Given this list of marker genes LAT, GP1BB, FAM3C, FDPS, TFRC, NUP107, ETF1, RRP1B, HK2, ACKR1, CLU, CHAC1, PBX1, KLF1, ST3GAL6, PLAGL2, TMEM132A, JMJD6, DIAPH3, ASNS, PFAS, ARHGAP29, TXNDC5, CTPS1, SLC2A1, NT5C3A, RABGEF1, RCOR1 (NCBI Gene Id 23186), IRAG1, GBX2, ZNRD2, TRMT61A, ZFPM1, GPAT4, PIGT, PDCD4, EGR1, NOMO1, TACC1, GUCY1A1, DCTD, FHL1, PARM1, MTHFD2, SCD, SHMT2, SEMA4B (NCBI Gene Id 56962), SLC1A4, EIF3D, PDGFB, PHLDA1, EXOC3L4, IPPK, LMO2, MRPL38, SKP2, PODXL, IPO11, SLC6A9, NSF, SLC2A3, GATA2, TMEM109, TCOF1, SLAMF1, DAAM1, PF4, E2F2, MTHFD1L, ACTB, AURKA, SIAH1, GOLT1B, here is a description of the gene set: Human Gene Set: HUANG_GATA2_TARGETS_DN GATA-2 is an essential transcription factor that regulates multiple aspects of hematopoiesis. Dysregulation of GATA-2 is a hallmark of acute megakaryoblastic leukemia in children with Down syndrome, a malignancy that is defined by the combination of trisomy 21 and a GATA1 mutation. Here, we show that GATA-2 is required for normal megakaryocyte development as well as aberrant megakaryopoiesis in Gata1 mutant cells. Furthermore, we demonstrate that GATA-2 indirectly controls cell cycle progression in GATA-1-deficient megakaryocytes. Genome-wide microarray analysis and chromatin immunoprecipitation studies revealed that GATA-2 regulates a wide set of genes, including cell cycle regulators and megakaryocyte-specific genes. Surprisingly, GATA-2 also negatively regulates the expression of crucial myeloid transcription factors, such as Sfpi1 and Cebpa. In the absence of GATA-1, GATA-2 prevents induction of a latent myeloid gene expression program. Thus, GATA-2 contributes to cell cycle progression and the maintenance of megakaryocyte identity of GATA-1-deficient cells, including GATA-1s-expressing fetal megakaryocyte progenitors. Moreover, our data reveal that overexpression of GATA-2 facilitates aberrant megakaryopoiesis. from publication Huang Z, Dore LC, Li Z, Orkin SH, Feng G, Lin S, Crispino JD (PMID 19620289) species: Mus musculus Genes down-regulated in G1ME cells (megakaryocyte/erythroid progenitor lacking GATA1) upon knockdown of GATA2 by RNAi.